Given this list of marker genes CD86, IFNGR1, MICA, MICB, CLEC2B, ICAM1, here is a description of the gene set: KSHV MIR2 to cell surface molecule-endocytosis. Pathway ID: N00185. Pathway type: Pathogen. Pathway class: nt06229 MHC presentation. studied in species Homo sapiens Pathway Definition from KEGG: MIR2 -| (ICAM1,CD86,MICA,MICB,CLEC2B,IFNGR1) Human Gene Set: KEGG_MEDICUS_PATHOGEN_KSHV_MIR2_TO_CELL_SURFACE_MOLECULE_ENDOCYTOSIS